Given this list of marker genes Clcf1, Ctf1, Lif, Il31ra, Tyk2, Il31, Il11ra1, Osmr, Cntf, Crlf1, Osm, Cntfr, Il11, here is a description of the gene set: Reactome Pathway: IL-6-type cytokine receptor ligand interactions electronically inferred by orthology from the curated human pathway studied in species Mus musculus This event has been computationally inferred from an event that has been demonstrated in another species.<p>The inference is based on the homology mapping from PANTHER. Briefly, reactions for which all involved PhysicalEntities (in input, output and catalyst) have a mapped orthologue/paralogue (for complexes at least 75% of components must have a mapping) are inferred to the other species. part of: Interleukin-6 family signaling